The following is a description of a gene set: from publication Cui Y, Zheng Y, Liu X, Yan L, Fan X, Yong J, Hu Y, Dong J, Li Q, Wu X, Gao S, Li J, Wen L, Qiao J, Tang F (PMID 30759401) Human Gene Set: CUI_DEVELOPING_HEART_C7_MAST_CELL studied in species Homo sapiens, and this is the list of marker genes: STING1, SERP1, SYAP1, PPP1R15A, BIN2, MBOAT7, SH3BGRL3, GATA2, SLC2A3, PRR13, HS3ST1, NFKBIZ, DNAJA1 (NCBI Gene Id 4737), CKS2, ATP2A3, ACSL4 (NCBI Gene Id 4426), BRD2, MIR23AHG, EIF5, EMP3, PNP, CTNNBL1, ARHGDIB, ENPP3, LYST, DNAJB1, PAG1, S100A6, VMP1, ADRB2, SRGN, ITGAM, CD53, ABRACL (NCBI Gene Id 58527), HCLS1, CAVIN2, PEPD, SDCBP, BTG2, ATP6V0A2, PIK3R6, PLIN2, RAC2, SIGLEC17P, CAPG, RNF130, RGS13, ALOX5, CD69, RGS2, MLPH, STXBP5, VWA5A, NABP1, HK2, IDI1, STX3, DOCK10, GLUL, HSPH1, PLEK, GMFG, HPGD, TMEM176B, LAT, RGS1, CREM, ELF1, MS4A2, LCP1, NCF4, S100A4, ARHGAP18, FCER1G, CSF2RB, FOSB, LPCAT2, CD37, ADAM8, GNA13, TESPA1, BATF, TPSB2, KIT, FXYD5, ELOVL5, CD83, UNC13D, C1orf162, CTSG, DUSP10, XBP1, RHOG, MPP1, HPGDS, SAMSN1, PTPN7, IER2, IL1RL1, CALB2, SERTAD1, SNX5, LIF, GRAP2, RHEX, ALDH1A1, TYROBP, VAMP8, HSPA1A, BST2, SLC18A2, LAIR1, IDS, ARHGAP15, SQSTM1, STXBP2, LINC01140, CD84, LAPTM5, CD44, ARHGEF6, CCNL1, TSC22D3, LPXN, ENSG00000233968, CNRIP1, TPSAB1, CLIC1, ANXA1, CLEC4OP, CAP1, DNAJB9, LTC4S, BTK, ALOX5AP, PRG2, ZFP36, CTSD, TENT5A, RHOH, GPR65, CPA3, TSPYL2, HDC (NCBI Gene Id 3067), NDST2, PTGS1, NFKBIA, TNFSF10, IFITM2, TPST2, SLC45A3, LAT2, P2RX1, TNFAIP3, BACE2, GAPT